Given this list of marker genes MGST3, TNFSF10, RTP4, MAP3K9, OGG1, HDAC1, GSR, CCNE2, CDA, DDIT3, MTFMT, CDK5, NFKBIA, MAP3K14, VTN, ATM, MAPK14, CDH1, SOS2, CTPS2, IFRD1, MPG, ERBB3, NOXA1, RAD54B (RAD54 homolog B), IRAK1, TK1, RRM1, CANT1, CEBPG, UPP1, MTAP, GSTK1, AURKB, TNFSF13, PNP (NCBI Gene Id 4860), CCNB1, TOP1, LEF1, RPS6KA5, PLAU, SOS1, ATF2 (activating transcription factor 2), CDC25A, AK4, IFRD2, PMVK, DNMT1, CDK2, TRADD (NCBI Gene Id 8717), CTH, FEN1, ECHDC2, BIRC5, TNFRSF12A, IRF7, IL1B, BIRC3, NME1, CALM1 (NCBI Gene Id 801), EBP, MYC, HSP90AA1, CDK1, NT5C, AKAP9, MET, NME2, CCNB2, POLQ, CDKN2B, MGST2, here is a description of the gene set: Methionine deprivation stress (MDS) eliminates mitotic activity in melanoma cells regardless of stage, grade, or TP53 status, whereas it has a negligible effect on normal skin fibroblasts. In most cases, apoptosis accounts for the elimination of up to 90% of tumor cells from the culture within 72 hours after MDS, leaving a scattered population of multinucleated resistant cells. Loss of mitosis in tumor cells is associated with marked reduction of cyclin-dependent kinase (CDK) 1 transcription and/or loss of its active form (CDK1-P-Thr(161)), which is coincident with up-regulation of CDKN1A, CDKN1B, and CDKN1C (p21, p27, and p57). Expression of the proapoptotic LITAF, IFNGR, EREG, TNFSF/TNFRSF10 and TNFRSF12, FAS, and RNASEL is primarily up-regulated/induced in cells destined to undergo apoptosis. Loss of Aurora kinase B and BIRC5, which are required for histone H3 phosphorylation, is associated with the accumulation of surviving multinucleated cells. Nevertheless, noncycling survivors of MDS are sensitized to temozolomide, carmustin, and cisplatin to a much greater extent than normal skin fibroblasts possibly because of the suppression of MGMT/TOP1/POLB, MGMT/RAD52/RAD54, and cMET/RADD52, respectively. Sensitivity to these and additional genotoxic agents and radiation may also be acquired due to loss of cMET/OGG1, reduced glutathione reductase levels, and a G(2)-phase block that is a crucial step in the damage response associated with enhancement of drug toxicity. Although the genes controlling mitotic arrest and/or apoptosis in response to low extracellular methionine levels are unknown, it is likely that such control is exerted via the induction/up-regulation of tumor suppressors/growth inhibitor genes, such as TGFB, PTEN, GAS1, EGR3, BTG3, MDA7, and the proteoglycans (LUM, BGN, and DCN), as well as the down-regulation/loss of function of prosurvival genes, such as NFkappaB, MYC, and ERBB2. Although MDS targets several common genes in tumors, mutational variability among melanomas may decide which metabolic and signal transduction pathways will be activated or shutdown. Genes down-regulated in MEWO cells (melanoma) after 96 h of methionine deprivation. from publication Kokkinakis DM, Brickner AG, Kirkwood JM, Liu X, Goldwasser JE, Kastrama A, Sander C, Bocangel D, Chada S (PMID 16908595) Human Gene Set: KOKKINAKIS_METHIONINE_DEPRIVATION_96HR_DN species: Homo sapiens